Given this list of marker genes GPR34, SKIL, DIO2, GLDN, PLEKHA3, LAMP3, OSBPL8, B4GALT6, TANC2 (NCBI Gene Id 80259), SGIP1, PTCHD4, SORBS1, DGKE, C1orf141, SAMD13, EMC6, SLC10A2, APELA, BZW1, SSPN, TMEM200A, DEPDC1, GABPA, LONRF1, SFI1, ZMYM4, TBC1D9, PRSS37, XPO4, RAB23, RIOK2, DPP8, OTUD6B, STMN3, CUL4B (NCBI Gene Id 8450), DCAF10, STAG2, SLC48A1, TEAD1, POC1B, KRT10-AS1, DHX8, FUT9, USH2A, LIF, SLC16A7 (solute carrier family 16 member 7), CTDSPL2, LSM8, MBTD1, LRP6, F5, NCOA5, HAS2, WASHC5, CNTNAP4, MYRIP, ELP4, ROBO2, LRRTM2, PYGO1, TMEM135, GXYLT1, CALM1, WWTR1, PRTG, HDAC9, LSAMP (limbic system associated membrane protein), SHLD2, GPRASP3, SOBP, PIK3CA, MAP4K5, GPHN, ZFP14, DAPP1, AGPS, CAMTA1, MYEF2, GABRB2 (NCBI Gene Id 2561), TMF1, CLDN8, AHSA2P, MORN4, PRICKLE2, IPO7, PHF20L1, ALCAM, GPC4, ZBTB10, KICS2, SYPL1, FAM76B, LRATD1, ERAP1, SEM1, LDAH, FAT3, ARMT1, USP7, SRP19 (signal recognition particle 19), ACVR2A, SQLE, BICRAL, HSD17B12, MBOAT2 (NCBI Gene Id 129642), AK3, MTDH, LCP2, USP38 (ubiquitin specific peptidase 38), NARS1, ANTXR2, METTL14, PRPS1, EIF3J, LINC03042, NCK1, IQGAP2, BECN1, DGKH, CTNNAL1, PTCHD1, PPP2R3A (NCBI Gene Id 5523), ZBTB34, ARRB1, ZNF347, MC2R (melanocortin 2 receptor), GPRASP2, VPS50, SLITRK2, KCNQ3, MED4, KIF4A, CCSER1, BCL11B, CTTNBP2NL (NCBI Gene Id 55917), PRP4K, PLAC8, NECTIN3, HNMT, OLFML2B, TMEM30B, TNFSF8, PPFIA1, CCAR1, KLF9, IGSF11, IKZF5, KLF5, MBTPS2, DENND4A (DENN domain containing 4A), MAP3K7, NCOA7, LAPTM5, CHRNA9, CMTM4, NAALADL2, CMC4, GLIS3, IPO9, BACH2, SNTB2, CD38, IRF8, ANKRD10, HABP4, TMEM229A, ELL2, CLEC12B, NDFIP2 (NCBI Gene Id 54602), QSER1, FRYL, MFSD6, ARHGAP28, ZNRF3 (NCBI Gene Id 84133), PGM2L1, DMGDH, OSBPL6, DCP2, GPR160, NTNG1, SRGAP1, KCNH8, ANGPT1, ZNF605, ETNK1, DNAJB14, AGFG1, PAPOLG, DNAI2, KIF11, ADAM22, SLC25A17, ZNF655, NTM (NCBI Gene Id 50863), HEY2, ZNF326, MAEA, NPAS3, GYPA, AQP4, ERAP2, DOCK1, CA13, SPA17, CFAP91, RASGRF2, CPLX4, KRTAP4-2, LACTB2, OGT, PCDH18, CNTN5, NCKAP5, NAPEPLD, LRRK2, SPIRE1, WWC2, RAP1A, PPP1CC, DBT, PABIR2, SAMTOR, IL22RA1, AJUBA, PRELID3B (PRELI domain containing 3B), PRDM10, FZD3, ANO10, ATE1, KLF12, LSM11, PPM1L, ZNF280C, UBL3, SLC7A13, NFIB, SNAP25, ING1, GNAT1, PTPDC1, GPC6, OXNAD1, PFDN4, MOB1B, MDH1, NANOG, WDR89, PNPLA8, LRRTM3, CLVS2, PJA2, CD2AP, C19orf12, APBB2, ITGA4, TAOK1, AHCTF1, CDH10, PKN2, SLC25A16, SHROOM3, CALN1, CRISPLD1, THSD7A, UVRAG, NR2F2, PARM1, TMEM45A, CDK6, CARD14, FAM83B, SWT1 (SWT1 RNA endoribonuclease homolog), FAM98B, PTGER3, ATAD1, XKR6, ANKRD27, ANGEL2, NOVA1, ITPR1, SULT1B1, APAF1, RIF1, MAP3K13, GJA1, CDC73, YPEL1, YTHDF3, ABI2, DIP2C, TMTC3, UGT3A1, ATP2C1, STAM, PAK3, FNIP1, TMEM233, ACTN2, UBE4A, YOD1, C2orf88, NSUN6, PHACTR2, CHSY3, SLC4A4, TRABD2B, ANKRD44, KCNN3, EAF1, NR4A3, TMSB4X, HSPA4L, FBXO33, NLGN1, HIPK2, C2CD5, CDK14, PHC1, LRRC19, SUMF1 (NCBI Gene Id 285362), CTCFL, IL6ST, MBNL3, TMEM215, FAM210A, KLHL9, MEGF11, PDP1, GPM6B, PDIK1L, CWF19L1, ZNF704, GLS, EPHA3, PCDHA2, CACNB4 (calcium voltage-gated channel auxiliary subunit beta 4), GSKIP, CAV2, GCOM1, SRP72, ZFX, SMIM15, AP1S2, ZFHX3, UQCC4, BMPR1A, SLC6A11, ZFHX4, SHC3, NCEH1, HOXD10, RHOQ, FNDC3A, MCTS1, ZC3H6, HSF5, SH3TC2, SETX, KCTD16, TMX4, RBFOX1, HDAC8, SH3GL3, NAA15, SEC24B, GPR180, TMEM220, TBL1XR1, PHLDB2, OXR1, COBLL1, COL4A3, GNAS, ANO5, SMIM14, ZBTB4, ERP44, MDGA2, RPRD1B, YTHDC2, TMED4, GNAQ, CAPZA1, DSCAML1, TMEM62, LGI1, ATP8A1, DISC1, DLG2, NEXMIF, ARSB, CADM2, PRKCB, CLIC5, STMN2, SELENOF, NKTR, HBS1L, CAPN7, CTNNA1, GUCY1A2, SMIM8, TPR, TULP4, STT3A, INSYN1, JRKL, RMND5A, GIPC2, NTRK2, CD1B, SLCO1A2, KLF7, RAB22A, DSC3, OMG, SENP6, CPT1A, HHIPL2, CFAP90, CEP57L1, UFL1, SLC6A2, RABGEF1, QKI, APC, KIAA1549L, MKX (mohawk homeobox), TIGAR, OGFRL1, SLC7A11 (NCBI Gene Id 23657), CAVIN4, SIRT1 (sirtuin 1), DENND4C, VGLL3, CSDE1, NVL, PATJ, RAB3B, LTBP1, CHM, CCNC (cyclin C), KLHL31, KIF5B, PSMD12, ACSL6 (NCBI Gene Id 56972), ZNF713, ACBD5, GOPC, TTC17, LRAT, SRBD1, ARL5A, PANK1, SPC24, STAG1, TBX22, C4orf17, MYO6, ETV6, LIMS1, OR51E2, NEDD4L, ZIC3, CHODL, NUS1, NET1, PHB1, RUFY2, ITGBL1, SORD, TENT5A, ZYG11A, FBXO21, GDPD2, NEK7, GPBP1, KIF2A, SPTLC3, PPFIA2, PHKB, B3GNT5, NPY5R, ANKIB1, SERINC1, JAG2, SH2D4B, POLR2M, IGSF5 (immunoglobulin superfamily member 5), PIK3R1, INSYN2A, ATP6V1C2, AFF2, PIAS2, RPS6KA3, ENTPD7, STXBP5, MAP1B, MAMDC2, YIPF6, OLIG3, SLC22A12, POU3F2, HOOK3, PHIP, TBC1D4, BRCC3, CCSAP, MMRN1, here is a description of the gene set: studied in species Homo sapiens from publication Chen Y, Wang X (PMID 31504780) Genes predicted to be targets of miRBase v22 microRNA hsa-miR-579-3p in miRDB v6.0 with MirTarget v4 prediction scores > 80 (high confidence targets). Human Gene Set: MIR579_3P